Given this list of marker genes TREM2, GBA1, CLU, NDP, IL34, CSF1R, CSF1, MAPK1, MIR181B1, CX3CL1, IL33, PTK2, MAPK3, here is a description of the gene set: The expansion of a macrophage population by cell division. species: Homo sapiens Human Gene Set: GOBP_MACROPHAGE_PROLIFERATION